Given this list of marker genes PLOD1, ATF6B, UBXN8, PSEN1, RDH10, ATG14, G6PC2 (NCBI Gene Id 57818), SHISA5, TLR8, CTAGE9, RINT1, SSR2, VMP1, MYORG, TMEM106C, BCAP31, RAB30 (NCBI Gene Id 27314), HLA-DRB1, NFE2L1, AGPAT1, UGT3A1, EMC2 (NCBI Gene Id 9694), RNF186, RAB29, SAMD8, FAXDC2, AP4E1, MPDU1, ATP9A, KDELR1, SPPL3, CERS6, ARFIP1, GOLGA8N, PICK1, WDR83OS, MTOR, LRRC8D, FUT4, DHRS9, TAB1, ARFGEF2, DOP1A (DOP1 leucine zipper like protein A), GRAMD2A, ERMP1, RNF103, PYURF, SYS1, COPB2, TMED2, ALG13, FUT6, CLSTN2, TAS2R16, P4HTM, SPINK5, SPTLC3, AFTPH, B4GALNT3 (NCBI Gene Id 283358), GNAS, RNFT1, MS4A6E, RHBDD2, CYP4F3, NR3C2, MAPK8IP1, STT3A, POMT2, SLC9A8, ATP11A, SOAT2, SGPL1, CEPT1, DOLPP1, CORO7 (coronin 7), MOGAT3, PTGFRN (NCBI Gene Id 5738), MARCHF5, ABHD12B, MBOAT7, SRP9, CYP4F8, FKBP1B, NSG2, AP1B1, RAB10, TMX3, LPGAT1, PIGS, CYP2C19, ATP7A, SCAMP4, STX8, CLTCL1, OCA2, EIF5A2, SDCBP, CYP4Z1, XXYLT1, RAC2, SORT1, CLBA1, TMEM199, NCEH1, FICD, EPM2AIP1, PDIA3, GRIN2B, ENTPD2, FADS2B, CDS2, RAB13, DOP1B, DENND5A, VAMP2 (vesicle associated membrane protein 2), RELCH, MAPKAP1, ATXN3, PIEZO1, RPS26 (NCBI Gene Id 6231), CLIP3, CYP7A1, GPAT4, ATP2A1, DNAJC16, BACE1, RNF121, ANKRD13C, ATP8B4, CNIH4, STIM2, RNF19B, RHBDD1, SEL1L, RASGRP1, CAMK2D, FA2H, TM4SF20, DPM2, SLC35D1, SSR3, EGFR, RTN1, SEC31B, IRAG2, VAMP3, NECAB3, TMEM129, HHATL, PTCHD3, HTR7, CDK5RAP3, APH1B, VCPIP1, FUT2, CHST4, TMED6, MRLN, ERGIC1, OST4, MR1, C17orf75, HSP90B1, IGF2R, SAR1B, WIPI1, TRAM1, ZC3H12A, RAB3GAP1, UBA5, PIGG, COPA, HAS2, NSF, POM121 (POM121 transmembrane nucleoporin), TMEM59 (NCBI Gene Id 9528), GOLGA8Q (golgin A8 family member Q), VMA21, B4GALT6, PITPNM1, ESYT1, ICMT, SEC13, ALG3, ARMC10, MCFD2, SBF1, RIC1, CYP2A7, LRBA, RAB38, ZW10, MLANA, POFUT2, SPCS1, AADAC, YIF1B, TMEM38B (NCBI Gene Id 55151), TECR, DPY19L4, VPS13A, EMC8, EXTL3, CDH1, AP1S1, ARL1, POMK, PIGX, FDFT1, TMX2, GRIN2A, PLPP7, FAF2, TLR7, BET1, ITPR2, FITM2, ARCN1, UBE2J2, SLC37A3, TMCC1, GOLGA8DP, LBR, CYP2S1, TEPSIN, CLVS1, BNIP3, GRM6, MGST1, PLA2G4C, FUT11, GAL3ST4, RAB2B, ZNRF4, DEGS1, RETSAT, CALN1, DUOXA2, DTNBP1, MYO18A, SRD5A3, JPH4, PCYT1B, B4GALT3, PANX2, SLC37A4, FTCD, CLGN, PGAP3, SIK2, AGTRAP, SPAST, SPCS3, ATG2A, ERMARD, SOAT1, SERP2, CERS4, TOR1A, CYP2E1, OSBPL6, CDK1, DNAJC25, PIGW, CD1D, VAMP5, PSKH1, SYVN1, STIM1, UCHL1, AKAP9, COPG1, ATXN2, CHST2, GOLT1A, SLC37A2, USP17L2, DPAGT1, SFTPA2, GUCY2C, STT3B, MYRF, RAB21, VTI1B, ORMDL2, PNLDC1, ATP11C, DDN, CLPTM1L, GRAMD4 (GRAM domain containing 4), SEC31A, TMTC2, EMC4, TSPO2, TMEM119, CAMLG, SPTSSB, PDZD8, MAP3K5, POSTN, PJA2, TMEM87B, CYP26C1, HPD, VAMP7, ERGIC3, TOR1AIP2, ACSL6, ULK1, YIPF2, TMED3, FOLR1, ALOX5AP, RAB8A, SLC10A7, RAB34, NAPEPLD, CTAGE4, FMN1, LPCAT4, SERINC1, TKT, IHH (Indian hedgehog signaling molecule), JSRP1, TMEM38A, FAM8A1, KCNK12, MOXD1, EDA, CISD2, FLRT1, ZDHHC9, LRRC8C, SLC9A7, PLAAT3, SLC30A7, TMPRSS3 (NCBI Gene Id 93657), SREBF2, WDR81, SLC39A1, BSCL2, HMGCLL1, AQP8, SEC23A, SLC35B1, ACSL3, STX16, STARD3NL, DNAJC18, HSD3B1, STING1, PLAUR, TMCC2, KDELR3, KIF13A, TEX264, ASAP2, EVA1A, DGAT2, EEF1A2, SC5D, SGCD, TMEM259, PLPP3, VPS54, SEC24C, HSD3B2, KTN1, HLA-B, PIP4K2B, UGT2A1, ARFGEF1, ST6GAL2, CYP2U1, CYP2C9, PTGES, DNAJB2 (NCBI Gene Id 3300), TRAPPC6B, MOB4, RHEB, JKAMP, ARL5B, DCSTAMP, ADPGK, ATP13A1, NOMO1, ECPAS, SCOC, ORMDL1, CREB3L2, SLC51A, TAPBPL, ALG5, RBFOX1, SEC16B, GDPD3, CLTC, PLPP2, HMGCR, TMEM174, CYP51A1, CD4, SELENOI, CYP1A1, TMEM115, LRIT1, SULF1, UBC, TMED9, HSD17B2, CCDC47, HACD2, GBA1, ALG12, SMIM6, HSD11B1, POMGNT2, GRAMD1C, SEZ6L2, TMEM165, LLGL1, ARFIP2, LRRC59, GPSM1, LPCAT1, LAMP2, COPE, EMD, DNAJA1, ZDHHC11, TMEM170A, CD74, ATP8A2, PGAP2, COPG2, ATP6AP2, PLP2, APH1A, CYP2R1, VRK2, CYBC1, FKBP1A, TAP2, PNPLA8, AP1G1, RETREG3, SRXN1, THADA, TUSC3, CTAGE6, PLEKHA8, COG3, BIRC6, GALNT2, TMEM41B, SLC36A2, NOMO2, SPTSSA, RPS28, SEC24B, PHETA2, MICALL1, TMEM97, STX4, GRIN3A, RGP1, ARHGAP32, PRKN, VKORC1, GOLGA2, RYR2, CYP26A1, B2M, SEC11A, FAM91A1, GGA1, DGAT1, SLC27A6, RAB1B, FKBP8, SEC11C, ALG1, CYP4F22 (NCBI Gene Id 50992), ACSL4 (acyl-CoA synthetase long chain family member 4), MME, USO1, DPY30, HACD4, PIGO, CRACR2A, EIPR1, ACP3, UGT1A3, CALR3, ACER3, VAPA, NSDHL, TXNDC11, SGMS1, CIMAP3, COG4, SEC16A, SFTPD, MGAT4A, ARAP1, FMO5, TMC8, RAB9A, TRPM1, COPB1, DUOXA1, TMBIM4, SPPL2B, IRGM, WFS1, HLA-C, RAC1, FZD6, NOTCH1, GOLIM4, MAP3K7, NRAS, TAPBP, G6PC1, FZD9, IER3IP1, UGT2B15, AP1S3, HACE1, SGCG, NOTCH4, INPP5E, CERS2, CYB5RL, PLD4, MEST, PLA2G2A, CNIH1, MS4A7, M6PR, SVIP, PORCN, PLEKHA3, ELOVL2, CNST, CA4, CYP2D6, RAB31, MBOAT1, PDIA5, SEL1L2, MYO1B, DIO2, SLC35A2, CHPF, SURF4, GJC1, CYP3A7, MX1, OSBP, ITPR1, AGPAT4, RHOC (NCBI Gene Id 389), FMN2, APOO (apolipoprotein O, NCBI Gene Id 79135), NSG1, ZDHHC2, RNF43, SLC9A6, ERP44, RAB6A, DHRS7C, GOLGA8O, GHITM, B3GALNT2, MAN2A1, UGT2B10, CSGALNACT1, CYP26B1, TMBIM6, GPER1, CLCC1, ERG28, EI24, CTAGE1, EIF2AK3, SRPRB, FUT9, POMT1, FAF1, CYP4X1, CSGALNACT2 (chondroitin sulfate N-acetylgalactosaminyltransferase 2), RAB18, PLCD4, AWAT1 (NCBI Gene Id 158833), AFG2B, ALG2, VTI1A, BSG, CYP7B1, TAP1, FMO2, DIPK1A, MGLL, ALG8, CLCN4, SLC11A2, WASL, LYSET, PANX1, TMEM201, OCRL, PLN, DHRS7B, RPN2, CFTR, SEC24D, PHETA1, SLC37A1, FCMR, ARL6IP1, LDAF1, GOLGA8S, MFSD2A, ELOVL7, SIGMAR1, SLC39A9, CPT1C, HMOX1, LAP3, CTDNEP1, LRRC8E, GOSR1, TPST2, CLTB, ATP6AP1, SLC27A3, DNAAF6, CANT1, ATL2, ALG10B, B4GALNT4, SLC30A6, RNF125, RAC3, ANXA7, FITM1, EXTL1, ST3GAL2, SLC66A2, CYP1B1, VCP, TLR3, CYBA, RTN3, AP1S2, CREB3L4, UBAC2, TRPM8, CCDC186 (NCBI Gene Id 55088), SLC30A1 (NCBI Gene Id 7779), CANX (calnexin), GBA2, HLA-E (NCBI Gene Id 3133), ATP7B (ATPase copper transporting beta), ACER1, SEC63, SERP1, SRD5A2, DHH, PARP16, COG5, CLVS2, HHAT (NCBI Gene Id 55733), TJAP1, NBEA, DPM3, UGT3A2, KLHL20, STX5, GRIA1, USE1, RP9, UBXN7, TMEM258, CHPF2, SLC18A1, FMO4, EXTL2, OPTN, RNF5, CLSTN1, HLA-DRB3, DERL1, UBA1, RTCB, FKBP2, STX17, SGCA, CERS5, CALHM1, GOLGA6A, RHBDF1, ERAP1, PLD3, APOB, BCAP29, UGT2B17, CREB3L1, CYP4V2, PAFAH2, REEP5, BLTP1, BACE2, CHAC1, SEC61A1, COG8, LRIT3, ART1, RAB11FIP3, TMEM39B, AREG, TBC1D23, OSBPL3, PLA2G4A, RNF183, NCSTN, ARL6IP5, SEC11B, CYP8B1, DIO1, B4GALT5, CBY1, ZDHHC22, CYP39A1 (cytochrome P450 family 39 subfamily A member 1), RDH12, RAB11A, ATP8B2, ABHD12, CYB5R2 (NCBI Gene Id 51700, cytochrome b5 reductase 2), IFNGR2, OTOF, MARCHF2, UGT1A10, PDIA6, CARD19 (NCBI Gene Id 84270), YIF1A, TUNAR, B4GALT1 (beta-1,4-galactosyltransferase 1), TMEM178A, HLA-H (NCBI Gene Id 3136), CYP4F11, MMP24, LNPK, ERN2, EPM2A, SPPL2A, ZFYVE27, ATP8B1, UGT1A7, USP19, SELENON, IKBIP, GOLGA6D, DAD1, YIPF1, RAB5IF, ERO1A, SNX9, RTN4, SLC27A4, HSD17B3, DNMBP, ST3GAL4, KCNA2, MIA3, AP1M1, GRIN2D, ARSL, DIPK1C (NCBI Gene Id 125704), MGAT4B, RCE1, TMCO5A, SLCO1B3-SLCO1B7, MGST2, CLN6, NAT8, MARCHF1, DISP3, KLHL14, TMEM132A, PITPNB, BAIAP3, CHST6, RPE65, SMPD3, TRIM59, RYR3, CAMK2B, DST, DEGS2, ARFRP1, PAPPA-AS1, HLA-DQB2, SGPP2, KLHL41, VKORC1L1, ALG6, UGT1A8, CYP4F12, CAV1, HLA-DQA2, B4GALT7, SMPD4, MMGT1, SLC16A11, FAAH, SYT11, SGPP1, AP4B1, ATP10D, GABARAPL2, HPN, PIGA, GOLGA8CP, CABP7, ZDHHC12, NSFL1C, CYB5R3, POR, BPNT2, CKAP4, CDS1, UBB, TMEM238L, CASP4, CLN3, UNC93B1, AGPAT5, FUT1, HLA-G, SMIM30, VPS52, PKD2, CHST5, MOSPD1, STRIT1, VPS13C, SGCZ, TRIM13, BFAR, WLS, ZDHHC20, SLC27A1, RNF180, TMEM39A, ATG13, MS4A6A, GALNT3, CLSTN3, COPZ1, FADS3, CHERP, GOLGA8T, PCSK5 (proprotein convertase subtilisin/kexin type 5, NCBI Gene Id 96284), SFTPC, LSS (lanosterol synthase), ZDHHC4, NDST1, STX6, DNAJC14, AGMO, PIGN, RDH11, CYP2W1, SCAP, RHBDF2, SLMAP, A3GALT2, CYB561D2, SEC61G, TGFA, GJA1, C4orf3, RNF13, ATP2A3, HLA-DQB1 (NCBI Gene Id 7924), TRAPPC9, XBP1, LTC4S, LMBRD1, RHOG, FUT7, INPP5K, HLA-F, ATP10A, PIGY, SEZ6L, ESYT3, RAB43 (NCBI Gene Id 339122), CERT1, RAB7B, DLG1, PARP6, BAX, NAGPA, CHRNA7, PCYT2, GPR89B, PLOD3, GGCX, TESPA1, PEDS1, AP4S1, TBXAS1, COG1, GBF1, PLOD2, PCSK4, CYP17A1, GOLPH3, ABCD1, PIGQ, LMF1, LGR6, COG6, RDH16, PPP1R15A, G6PC3, GOLGA1 (golgin A1), ST6GAL1, BECN1, NMNAT2, DHCR7, ERLIN1, GAL3ST2, PHTF1 (NCBI Gene Id 10745), ABCB9, PIGM, STBD1, ERGIC2, MIA2, DNM1L, CAMK2G, SHH, LMAN1, GPAT3, CASQ1, CTAGE15, RYR1, MLEC, SGMS2, PTGS2, DMPK, DNAJB14, PANX3, ELOVL6, TMEM147, PREB, KCNK2, PTGDS, PPM1L, PIGK, CYBB, GAL3ST3, RNF26, AP1M2 (adaptor related protein complex 1 subunit mu 2), OTULINL, MGAT4D, MARCHF9, PLPP6, GDPD1, RNF185 (ring finger protein 185), FLVCR2, SLC28A3, TRIQK, TMEM86A, ATP2A2, TMEM63C, MACO1, TMCC3, XK, CHRM3, CYB5B, SCAMP2, MOGAT1, ALG10, ATP8A1, TMEM68, SULF2, SREBF1, PCSK7, P2RX6, PLEKHJ1, SHISA3, RB1CC1, SELENOK, FADS2, DHRS7, C2CD2L, JPH2, TRAPPC4, EMC7, ELOVL1, GRIN2C, GET3, ATP10B, EMC6, GRAMD1A, TMEM208, ABCB6, HLA-DRB5, ZMPSTE24, GCNT1, GRIN1, FLRT2, CHID1, GGTA1, SLC17A3, CYP2A13, ATP2C1, BICD1, TMEM98, STEEP1, GOLPH3L, ACSL5, PROS1, ASAP1, TGOLN2, REEP3, TMEM43 (NCBI Gene Id 79188), SSR1, GUCY2D, PNPLA7, GABBR1, OS9, ST3GAL3, SLC35B2, HLA-DQA1, FUT10, SCAMP3, TRDN, PIGH, APOL2, TYRO3, GOLGA7, ZDHHC16, COG2, CYP46A1, LRRC8B, PIK3R1, LMAN2L, ARL5C, RNF175, CASQ2 (calsequestrin 2), LGR5, CYP1A2, RPN1, TMEM79, TMEM86B, EPHX1, GORASP2, MSMO1, RASIP1, DNAJB9, CREB3L3, SERAC1, CLN8, TMEM260, GGA2, PIGT, ANO5, ATG9B, PGAP1, ABCC6, DHRS3, GALNT1, UGT1A9, CLIC4, GPAA1, UBIAD1, EMC10, NCLN, TRAM2, DGAT2L6, CYP21A2, MGAT2, PIGZ (phosphatidylinositol glycan anchor biosynthesis class Z), UGT2B4, PLD1, UGT1A6, SAYSD1, ITPR3, LCLAT1, PIGV, ELAPOR1, HRAS, EDEM1, CD59, KPNB1, TMX4, STIMATE, APP, DPY19L1, GOLGA8R, LPCAT3, TEX2, ALG11, TBL2, TRAPPC6A, YIPF4, UBE2J1, ABCC12, CH25H, CRYZL2P-SEC16B, SLC27A5, AHCYL1, DHCR24, TAPT1, SEC22C (SEC22 homolog C, vesicle trafficking protein), ABCA1, ANKS4B, CD2AP, SEC23B, IFI6, VPS13B, GCC2, RIC3, PTGIS, SMIM14, CTAGE8, SEC62, SORL1, SLC35G1, SGCB, SRI, UGT2A2, GSG1, SDR16C5 (short chain dehydrogenase/reductase family 16C member 5), RETREG2, DAG1, SYNE2, CLASP2, STX18, GRN, CIDEB, MBOAT4, GJB1, TPTE2, KIAA0319L, CALU, GPR37, HSD11B2, PSENEN, MCTP1, MMP23B, SUCO, SLC43A1 (solute carrier family 43 member 1), MRAP, LMF2, CDC14C, TMEM94, RPS27A, CCDC91, ERN1, RPS29, SEC24A, ORMDL3, HSD3B7, DERL3, DSE, SLC30A5, TBC1D20, XYLT1, HSD17B7, TMEM67, SEC22A, LPIN1, DPY19L3, GOLGA8K, GPR108, SFTPB, C8orf17, TMEM14A, HLA-DPB1, LCTL, MINAR2, AZIN2 (antizyme inhibitor 2), TAAR1, ARV1, AUP1, MBOAT2, TTYH1, HMOX2, MOGS, BCL2, YIPF6, PTPN5, PSEN2, COPZ2, EMC9 (NCBI Gene Id 95655), PTGS1, ALG14, PRKD1, SPPL2C, REEP4, ZFYVE1, CYP4A11, SLC35D3, AGPAT2 (NCBI Gene Id 681), NPLOC4, SLC2A4, UGT8, VAPB, LYPLA2, VAMP4, HTRA2, HID1, PNPLA3, BLTP2, ABO, STARD3, PNPLA2, RAB2A, PARP8, SLC35B3, ZDHHC6, SCAMP5, DOLK, RHOA, ATL3, ZFAND2B, UBXN1, SGCE, SARAF (store-operated calcium entry associated regulatory factor), TMEM87A, JPH3, GOLGA5, HACD1, PHAF1, SYT17, MAGT1, YIPF7, REEP6, CREB3, RNF41, RSAD2, OSBPL8, BNIP1, CHSY3, CYP4F2, DHDDS, SEC22B, FUT3, TMEM230, SCARB2, USP6NL, ABCD4, SCFD1, TMEM50B, UFD1, CYP2C8, IFI27 (NCBI Gene Id 3429), TOM1L1, MBTPS1, SLC24A5, ERLIN2, TMC6, EIF5AL1, TM6SF2, ILVBL, TMX1, ANKLE2, PEMT, HLA-DRB4, PDGFRA, IZUMO1, SFTA3, SLC39A7, NOMO3, HLA-DRA, UPK3A, GOLGA8M, DDOST, FRRS1L, LRRK2, TMED4, GNAI3, AWAT2, CYB5R1, TMT1B, CYB5R4, PON1, GOLGA3, ANTXR2, NOTCH2 (notch receptor 2), LRAT, GNRH1, MARCHF8, RAB14, GOLGA8J, B4GALT2, AQP11, DNAJB12, HERPUD1 (NCBI Gene Id 9709), SACM1L, ELOVL4, UFL1, TPST1, FXYD3, PCSK1N, CYP2A6, SLC39A13, PDCD6, UGT2B7, ADGRG6, RNF170, TLR9, SELENOS, UGT2B11, HM13, CYP3A4, PI4K2A, SLC35B4, MRAP2, HACD3, ATP8B3, NOTCH3, MBLAC2, CYP2F1, STX10, NDRG4, ABCG1, VPS53 (NCBI Gene Id 55275), GOLGA6C, SNAP25, CYP2B6, HSPA5, POM121C, GIMAP1, IRAG1, TMED5, B3GLCT, PMEL, GOLGA6B, GRAMD1B, EXT2, NOX5 (NADPH oxidase 5), AP4M1, NOX4, SQLE, FKBP1C, ZDHHC14, SPTLC1, DNAJC1, HOOK2, RICTOR (RPTOR independent companion of MTOR complex 2), PI4K2B, BET1L, CNIH3, CERS1, RNF133, PIGU, EIF5A, SEC61A2, UBXN4, WDR11, LPIN2, TEX261, RTN2, OSBPL7, TGFBI, SRD5A1, RHOBTB3, MGST3, ALDH3A2, RAB27B, MOSPD2, GSAP, PTDSS2, MARCHF6, PIK3C2A, TRAM1L1, REEP1, SPTLC2, RNF139, KDSR, MOGAT2, TM7SF2, SLN, YIPF5, SCAMP1, ZDHHC1, VRK1, ATP13A4, PNPLA6, OSTC, KRAS, EBP, SHISA2, TMED1, PIGP (phosphatidylinositol glycan anchor biosynthesis class P), PREPL, GOSR2, DDRGK1, AGPAT3, EXT1, DHRS4, RNF145, LMBR1L, MARCHF4, ILDR2, SLC26A9, ATG101, AMFR, CHODL, KSR1, TMED7, GPR89A, PON3, SEC61B, RDH14, SLC33A1, TMED10, ATP2C2, NAT8L, PIGF, VPS51, HLA-DPA1, NEU4, TMEM109, STS, ACSL1, ASPH, TREX1, FMO1, TMEM214, RAB32, ATF6, NRROS, BOK, JAGN1, PKMYT1, TMEM35A, UBA52 (NCBI Gene Id 7311), HTN1, PIGL, KCNK16, CLTA, CYP3A43, HSD17B12, RRBP1, DRD1, UBQLN4, ATP9B, RGS20, CERS3, DPM1, CNIH2, TLCD3B, GOLGB1, B3GALT6, SRL, ATG2B, RETREG1, CYP4A22, TMEM203, SELENOT, ALG9, CSPG5, TMEM151A, EMC1, UGT1A1, PI4KB, MYRFL, RAB3GAP2, SPCS2, ERO1B, RNF144A, FATE1, ERAP2, CYP2J2, ELOVL3, SCD5, CHSY1 (chondroitin sulfate synthase 1), ST3GAL1, GOLGA8B, NOS1AP, B3GAT1, JPH1, PLD2, NAT8B, INSIG2, MAN1B1, FMO3 (NCBI Gene Id 2328), PLK3, SRPRA, KRTCAP2, PNPT1, RABEPK, RDH5, OSBPL5, AKAP6, NUS1, EBPL, SCD, IL15RA, LPIN3, GGA3, KPNA2, PCYT1A, CALR, INSIG1, FLRT3, FURIN, CYP3A5, CYP2C18 (NCBI Gene Id 1562), UGT2B28, FADS1, COG7, RASGRF2, MYMX, PEX16, DERL2, GOLGA8IP, GOLGA8A, LPCAT2, RFT1, GET1, PTPN1, GOLGA8H, UGT1A4, FUT5, PGRMC1, REEP2, TRAF2, GRIP1, ABHD4 (NCBI Gene Id 63874), CACFD1, MTDH, GOLGA4, FREY1, CDIPT, TMCO1, PIGB, ATG9A, PML, FUT8, PTDSS1, NUP210 (NCBI Gene Id 79985), ELOVL5, NBAS, ARL5A, EMC3, KDELR2, SFTPA1, CHPT1, CYP4B1 (cytochrome P450 family 4 subfamily B member 1), SSR4, CYB5A, SGK1, PIGC, LMAN2, NOS1, ATL1, ESYT2, UXS1, SCARA3, CYP19A1, LMAN1L, SAR1A, CDC42, HLA-A, TMEM33 (NCBI Gene Id 55161), SLC27A2, GCC1, UGT1A5, RPL27, SLC8A3, DIPK1B, CDKAL1, here is a description of the gene set: Human Gene Set: GOCC_ORGANELLE_SUBCOMPARTMENT A compartment that consists of a lumen and an enclosing membrane, and is part of an organelle. species: Homo sapiens